Given this list of marker genes CDKN1C, CCNT2, PDCL, PCDH9, TERF2, MED6, TP53, COX6A1, MPDU1, IRF1, GSTT2, FRAT2, ADO, ZKSCAN1, BUD23, CTH, LACRT, SAT1, ALDH1B1, TRIM21, RPUSD2, RAD9A, CASP3, HAUS3, GLS, here is a description of the gene set: from publication da Costa RM, Riou L, Paquola A, Menck CF, Sarasin A (PMID 15608684) species: Homo sapiens Genes exclusively up-regulated in fibroblasts expressing the XP/CS mutant form of ERCC3 after high dose UVC irradiation. Human Gene Set: DACOSTA_UV_RESPONSE_VIA_ERCC3_XPCS_UP Xeroderma pigmentosum (XP) and trichothiodystrophy (TTD) syndromes are characterized by deficiency in nucleotide excision repair pathway, but with distinguished clinical manifestations. While XP patients exhibit a high frequency of skin cancer, TTD patients are not cancer prone. The relation between lack of DNA repair and their clinical manifestations was investigated through analysis of the transcriptional profile of 12,600 transcripts in two isogenic cell lines with different capabilities of DNA repair. These cell lines result from a stable transfection of the XPB-TTD allele into XP complementation group B fibroblasts, from an XP patient who also have clinical abnormalities corresponding to Cockayne's syndrome (CS). The microarray assays performed under normal growth conditions showed the expression of distinct groups of genes in each cell line. The UVC-transcription modulation of these cells revealed the changes in 869 transcripts. Some of these transcripts had similar modulation pattern in both cells, although with eventually different time patterns for induction or repression. However, some different 'UVC signature' for each cell line was also found, that is, transcripts that were specifically UV regulated depending on the DNA repair status of the cell. These results provide a detailed portrait of expression profiles that may potentially unravel the causes of the different phenotypes of XP/CS and TTD patients.